Given this list of marker genes CYP2D6, UGT1A1, SLCO1B1, UGT1A8, UGT1A6, UGT1A10, CYP3A4, UGT2B7, CYP2C8, ABCC2, ABCB1, UGT1A9, ABCC3, UGT2B4, here is a description of the gene set: Codeine and morphine metabolism Human Gene Set: WP_CODEINE_AND_MORPHINE_METABOLISM species: Homo sapiens